Given this list of marker genes TSC2, IFNG, TSC1 (NCBI Gene Id 7248), DIS3L2, CDC73, CDKN1B, MVK, here is a description of the gene set: Renal hamartoma A disordered proliferation of mature tissues that are native to the kidneys. Human Gene Set: HP_RENAL_HAMARTOMA species: Homo sapiens